Given this list of marker genes SYK, VAV1, PIK3CB, PIK3CD, FYN, YES1, BLNK, CBL, PIK3R3, GRB2, PIK3R1, RPS27A, CRK, UBA52, PIK3R2, UBC, RAPGEF1, LYN, CRKL, UBB, HCK, PIK3CA, here is a description of the gene set: studied in species Homo sapiens Regulation of signaling by CBL Human Gene Set: REACTOME_REGULATION_OF_SIGNALING_BY_CBL